Given this list of marker genes Mmp14, Kcne2, Prelid1, Nub1, Sirt6, Timm23, Ctnnd1, Gba1, Hspbp1, Ist1, Socs5, Zfand2a, Antxr1, Ddrgk1, Nop53, Dvl1, Ube2v2, Aph1a, Rad23a, Cdc20b, Cln6, S100a10, Rgn, Cldn4, Atp5if1, Akt1, Adam9, Gsk3a, Csnk1d, Gsk3b, Pias1, Casp8, Tgfb1i1, Bak1, Gpld1, Eif2a, E330034G19Rik, Agbl4, Hspa1b, Fgfr4, Sumo1, Cyfip2, Atg7, Ctsc, Rhbdd1, Zyg11b, Ubqln2, Cfl1, Rgma, Disc1, Smurf1, Pabir1, Dnajb2, Ager, Trim32, Fuz (NCBI Gene Id 70300), Atxn3, Usp13, Rnf185, Fbxw11, Ccbe1 (collagen and calcium binding EGF domains 1), Spon1 (spondin 1, (f-spondin) extracellular matrix protein), Ptk2, Rnft1, Trib2, Tbc1d10a, Hpn, Angptl8, Sumo3, Tnfrsf1b, Ubqln1, Myh9, Cbfa2t3, Osbpl7, Cntn2, Aurkaip1, Rnf139 (ring finger protein 139), Sumo2, Anxa2, Ptk2b, Ifng, Grn, Apoe, Eno1b, Il1b, Mapk8, Aph1b, Hamp, Cdc20, Trib1, Nkd2, Clu, Chfr, Plk3, Fbxw7, Gclc, Paqr3, Axin1, Mapk9, Axin2, Tank, Gabarap, Sgta, Fmr1, Rnft2, Fadd, Mtor, Klhl40, Tnp2, Sh3rf2, Det1, Sh3rf3, Lyn, Oga, Bcap31, Fbxo22, Mbp, Rchy1, Prss22, Capn3, Btrc, Efna3, Tnf, Bag2, Lrrk2, Cav1, Trib3, Oaz1, Rcn3, Rack1, Traf7, Vsir, Wfs1, Gsn, Ufl1, Cldn3, Cop1, Aurka, Rnf180, Asph, Pacsin3, Usp5, Efna1, Tmem259, Epha4, Cd46, Stub1, App, Snx33 (sorting nexin 33), Psmd10, Agtpbp1, Ern1, Cldn13, Perp, Rbx1-ps, Mbl2, Pten, Tmtc3, Xbp1, Vcp, Tmx1, Ogt, Nlrc4, Cdk5rap3, Adra2a, Nrdc, Snx9, Sh3d19, F12, Psen1, Rnf40, Stat3, Socs4, Egf, Hspa1a, Il33, Plk1, Prkn, Bag6, Meltf, Rbx1, Adam8, Prickle1, Ccdc22, Psenen, Psen2, Sirt2, Bad, Hspa8, Herpud1, Eno1, Ep300, Sfrp2, Dda1, Plgrkt, Laptm5, Trf, Aph1c, Dab2, Trim67, Dab2ip, Plk2, Astl, Tmem67 (NCBI Gene Id 76678), Csnk1e, Csnk1a1, L3mbtl3, Eif2ak3, Timm17a (NCBI Gene Id 21854), Zer1, Src, Ncstn, Mdm2, Bbs7, Clec3b (C-type lectin domain family 3, member b), Sh3rf1, Fbxw8, Trem2, Sirt1, Tnp1, Ctsh, Fzr1, Nupr1, Ecscr, Hdac2, here is a description of the gene set: Mouse Gene Set: GOBP_POSITIVE_REGULATION_OF_PROTEOLYSIS studied in species Mus musculus Any process that activates or increases the frequency, rate or extent of the hydrolysis of a peptide bond or bonds within a protein.